Given this list of marker genes Kif1b, Kif3c, Actn4, Ccnb2, Apc, Dst, Dynll2, Tpx2, Arhgef7, Fgd4, Ralbp1, Rhot2, Hdac6, Wasf1, Plk1, Atg4b, Arhgef12, Nedd9, Map3k11, Rab3gap1, Fgd6, Myh9, Uxt (NCBI Gene Id 319632), Sptbn1, Cdk5rap2, Tubgcp5, Nck1, Shroom1, Akap13, Ywhae, Abl1, Bcar1, Wasl, Kifap3, Myh10 (NCBI Gene Id 77579), Ckap5, Csnk1d, Anln, Rictor, Cep57, Pcm1, Alms1, Wasf2, Ttk, Tubgcp3, Lats1, Katna1, Incenp, Arl8a, Kif4, Ezr, Cntrl, Map1s, Cdc42bpa, Ophn1, Synpo, Stk38l, Cdc42ep1, Myo1e, Pcnt, Epb41l2, Septin9, Nf1, Rapgef5, Tuba4a, Prc1, Smc1a, Tbcd, Pif1, Tlk1 (tousled-like kinase 1), Sos1, Arap3, Smc3, Myo9b, Klc1, Arhgap29, Itsn1, Katnb1, Rasa1, Cenpf, Rasal2, Mapre1, Ranbp9, Tubgcp6, Sac3d1, Tubgcp2, Bin1, Cep250, Racgap1, Ndc80, Abr, Rabgap1, Pafah1b1, Smc4, Nusap1, Cyth2, Dock4, Flnb, Nin, Cdc42ep2, Kif23, Arhgef2, Clip2, Mid1, Trio, Dlgap5, Rfc1, Mid1ip1, Brca2, Vcl, Kif15, Rock1 (NCBI Gene Id 68785), Dlg1, Arhgap10, Cttn (cortactin), Bub1, Espl1, Arhgap27, Arhgdia, Tubd1, Llgl1 (LLGL1 scribble cell polarity complex component), Fscn1, Plekhg2, Cep72, Arhgef11, Tiam1, Cdc42ep4, Cdc42, Bcr, Nck2 (NCBI Gene Id 74592), Marcks, Gsn, Flna, Farp1 (NCBI Gene Id 223254), Dync1h1, Sass6, Arhgap4 (Rho GTPase activating protein 4), Kif2c, Kif20b, Aurka (NCBI Gene Id 99385), Tsc1, Arf6, Top2a, Sun2, Als2, Palld, Clip1, Cenpj, Ppp4r2, Gemin4, Notch2, Shroom2 (NCBI Gene Id 670546), Lrpprc, Ect2, Pkd2, Nek2, Taok2, Ssh2, Cep192 (NCBI Gene Id 70799), Kptn, Capzb, Kntc1, Numa1, Cdc27, Mark4, Pcgf5, Net1, Cntrob, Rapgef6, Birc5, Bcl2l11, Arhgef3, Kif11 (kinesin family member 11), Sptan1, Arfip2, Abi1, Rasa2, Clasp1, Fbxo5, Hook3, Epb41, Lmnb1, Kif5b, Pxn, Rhof, Dock2, Cd2ap, Prex1, Pdlim5, Cdk1, Ccdc88a, Sorbs2, Kif22, Arhgap5, Kif3b, Cep131, Arfgef1, Cenpe, Stau1, here is a description of the gene set: from publication Howe DG, Blake JA, Bradford YM, Bult CJ, Calvi BR, Engel SR, Kadin JA, Kaufman TC, Kishore R, Laulederkind SJF, Lewis SE, Moxon SAT, Richardson JE, Smith C (PMID 30224793) Mouse Gene Set: HALLMARK_MITOTIC_SPINDLE Mouse genes annotated to HALLMARK_MITOTIC_SPINDLE based on orthology mappings provided by the Alliance Genome Consortium studied in species Mus musculus